Given this list of marker genes Snx4, Rab3a, Ap1g1, Crhr1, Adora2b, Adora3, Ptafr, Fcer1a, Syt4, Cdk5r2, Nppa, Ms4a2, Pld2, Cacna1i, Cdk5, Rph3al, Itgb2, Stx4a, Sphk2, Il4, Arf1, Syt9, F2rl1, Cacna1h, Cacna1d, Il13, Syk, Fgr, Lypd11, Lamp1 (lysosomal-associated membrane protein 1), Cadps (Ca2+-dependent secretion activator), Stxbp2, Scamp5, Itgam, Unc13d, Lypd10, Nlgn1, Gata1, Dnm1l, Rph3a, Rab15, Stx1a, Syt1, Cd160, Il4ra, Itgb2l, Hyal3, Fcer1g, Nppc, Doc2a, Doc2g, Slc4a8, Syt7, Rab27a, Cacna1g, Kcnb1, Vamp8, Zp3, Cd177 (NCBI Gene Id 68891), Rab3d, Doc2b (double C2, beta), Syt10, Pla2g3, Bcl2l1, Gata2, Gab2, Stxbp1, here is a description of the gene set: Any process that activates or increases the frequency, rate or extent of regulated secretory pathway. studied in species Mus musculus Mouse Gene Set: GOBP_POSITIVE_REGULATION_OF_REGULATED_SECRETORY_PATHWAY